Given this list of marker genes KCNQ2, DMXL2, TPK1, SLC6A19, SLC1A3, CACNB4, PDHA1, OTC, SIK1, SCN2A, NFIX, SLC32A1, SLC25A22, SCN1B, NEUROD2 (neuronal differentiation 2), GRM7, PIGP, ARX, GRIN1, KCNA1, CDKL5, CACNA1A, TRIM8, ATP1A2, ATP1A3, PIGQ, GNAO1 (NCBI Gene Id 2775), CASK (calcium/calmodulin dependent serine protein kinase), SLC2A1, PNKP, here is a description of the gene set: Episodic ataxia Periodic spells of incoordination and imbalance, that is, episodes of ataxia typically lasting from 10 minutes to several hours or days. Human Gene Set: HP_EPISODIC_ATAXIA studied in species Homo sapiens